Given this list of marker genes TWIST1, PIK3CD, EYA1, PTDSS1, SPRED2 (sprouty related EVH1 domain containing 2), FGFR3, SIX1, TP63, KAT6A, MED12, FGFR2, TCOF1, PPP1CB, NIPBL, TET3, KNSTRN, YY1, SF3B4, CD151, PAX1, here is a description of the gene set: species: Homo sapiens Human Gene Set: HP_LACRIMAL_DUCT_STENOSIS Lacrimal duct stenosis Narrowing of a tear duct (lacrimal duct).